Given this list of marker genes CCL26, CCL27, NARS1, CCL24, CCL11, here is a description of the gene set: Binding to a CCR3 chemokine receptor. species: Homo sapiens Human Gene Set: GOMF_CCR3_CHEMOKINE_RECEPTOR_BINDING